The following is a description of a gene set: Down-regulated at 24 h following infection of primary human foreskin fibroblasts with CMV Mechanistic insights to viral replication and pathogenesis generally have come from the analysis of viral gene products, either by studying their biochemical activities and interactions individually or by creating mutant viruses and analyzing their phenotype. Now it is possible to identify and catalog the host cell genes whose mRNA levels change in response to a pathogen. We have used DNA array technology to monitor the level of approximately 6,600 human mRNAs in uninfected as compared with human cytomegalovirus-infected cells. The level of 258 mRNAs changed by a factor of 4 or more before the onset of viral DNA replication. Several of these mRNAs encode gene products that might play key roles in virus-induced pathogenesis, identifying them as intriguing targets for further study. studied in species Homo sapiens from publication Zhu H, Cong JP, Mamtora G, Gingeras T, Shenk T (PMID 9826724) Human Gene Set: ZHU_CMV_24_HR_DN, and this is the list of marker genes: RAB13, CD151, PTGIS, IGFBP5, ANPEP, AHR, RUNX1, VCAN, CXCL12, MATK, TENT5A, TRAM2, COL1A2, CCND1, IGF2, ABL1, F7, HIVEP2 (HIVEP zinc finger 2), FLNA, COL1A1, TNNI3, TMEM198B, POSTN, TPM2, SULT1E1, LAMB2, COL5A2, BCL2, GPX1, C7orf50, C1R, CHN1, AKR1C1, ADRA2A, LOX, COL6A2, LAMA4, ADM, PDGFRA, PYCR1 (pyrroline-5-carboxylate reductase 1), THBS2, MITF, CRHBP, ID2, CNN2, TFAP4, ACO1, SERPINE1, EFEMP1, XPC, EPO, WEE1, TPM4, CYP1B1, ACTG1, HSD17B2 (hydroxysteroid 17-beta dehydrogenase 2), NFIC, CFD, TIMP3, TGFBR3, TAGLN, PTPN13, IGFBP3, COL3A1, MYLK, FTL, THBS1, CDH11, IGF1R, SGCG, FKBP10, ACTA2, ACKR3, UBL4A, SERPINB6, PABPC1, DDR2, GAS1, MBL2, ANXA1, PAFAH1B1, MN1, TNFRSF1A, NR3C1